Given this list of marker genes TFAP2A, SUMO2, SUMO1, PIAS1, PIAS3, UBE2I, SP3, TFAP2C, PIAS2, PIAS4, FOXL2, MITF, TP53BP1, CDKN2A, MDM2, TP53, MTA1, HIC1, SUMO3, TFAP2B, here is a description of the gene set: species: Homo sapiens Human Gene Set: REACTOME_SUMOYLATION_OF_TRANSCRIPTION_FACTORS SUMOylation of transcription factors